The following is a description of a gene set: Mouse Gene Set: GOMF_CYSTEINE_TYPE_ENDOPEPTIDASE_INHIBITOR_ACTIVITY_INVOLVED_IN_APOPTOTIC_PROCESS species: Mus musculus Binds to and stops, prevents or reduces the activity of a cysteine-type endopeptidase involved in the apoptotic process., and this is the list of marker genes: Tnfsf14, Bcl2a1d, Vil1, Xiap, Rps6ka3, Naip1, Dpep1, Birc2, Serpinb9, Snca, Serpinb9b, Rps6ka1, Tnfaip8, Birc3, Bcl2l1, Birc5, Naip5, Serpinb9h, Naip6, Serpinb9d, Nol3, Prdx3, Serpinb9f, Serpinb9c, Prdx5, Avp, Birc7 (baculoviral IAP repeat-containing 7), Gas6, Naip2, Serpinb9e, Cd27, Serpinb9g